The following is a description of a gene set: Central primitive neuroectodermal tumor species: Homo sapiens A primitive neuroectodermal neoplasm that occurs in the central nervous system. Human Gene Set: HP_CENTRAL_PRIMITIVE_NEUROECTODERMAL_TUMOR, and this is the list of marker genes: TP53, CDKN2A, CHEK2, MDM2, KEAP1, DICER1